Given this list of marker genes Nol4, Purb, Utp25, Ank1, Rab11fip1, Sec22b, Pax9, Crb3, Aak1, Pcdh17, Khnyn, Zmat4, Polr3a, Celf1, Szrd1, Glo1, Hamp (NCBI Gene Id 84506), Ap1g1, Mamstr, Nfatc3, Ttc21b, Zfp715 (NCBI Gene Id 69930), Acvr2b, Ddi2, Cetn2, Capn2, Epha7, Ggct, Cmip, Cass4, Fnip1, Sp140l1, Tsr1, Adam12, Saal1, Tnfsf8, Arhgap29, Ceacam20, Tpm3, Mmp14, Rab39b, Pdss2, Pabpn1, Wdr73, Pten, Tlnrd1, Zfp800, Fermt2, Dner, Cped1, Serpinb10, Sh3bp5, Bclaf1, Il18bp, Zc3h15, Sumf1 (sulfatase modifying factor 1), Xndc1, Gpsm2, Sumf2, Ddo, Tmem37, Wdr82, Spred3, Nme7, Cyp26b1, Cstf1, Dlc1, Extl2, Rhod, Kif12, Hamp2, Crxos, Epha4 (NCBI Gene Id 98323), Mtmr4, Mettl2, Osbpl3, Slc25a24 (solute carrier family 25 (mitochondrial carrier, phosphate carrier), member 24), Gpr3, Rps6, Acadsb, Hhip, Pde1a, Ankk1, Ciita, Phip (NCBI Gene Id 83946), Klf6, Fam91a1, Heph, Smyd2, Prkaa2 (protein kinase, AMP-activated, alpha 2 catalytic subunit), F8a, Slc32a1, Cntd1, Serpina3j, Ppp2r3a, Dyrk1a, Ndrg2, Rfxap (NCBI Gene Id 320768), Ankib1, Rimbp2, Pcdh19, Rgs2, Ttc39c, Olfml1, Arhgef33, here is a description of the gene set: Genes predicted to be targets of miRBase v22 microRNA mmu_miR_124b_3p in miRDB v6.0 with MirTarget v4 prediction scores > 80 (high confidence targets). from publication Chen Y, Wang X (PMID 31504780) species: Mus musculus Mouse Gene Set: MIR_124B_3P